The following is a description of a gene set: species: Homo sapiens Human Gene Set: GOBP_LOOP_OF_HENLE_DEVELOPMENT The process whose specific outcome is the progression of the loop of Henle over time, from its formation to the mature structure. The loop of Henle is a nephron tubule that connects the proximal convoluted tubule to the distal convoluted tubule., and this is the list of marker genes: POU3F3, PKD1, PKD2, IRX2, IRX3, UMOD, DLL1, HES5, WNT7B, AQP1, IRX1, JAG1